The following is a description of a gene set: Scrapie conformation PrPSc to PERK-ATF4 signaling pathway. Pathway ID: N01198. Pathway type: Variant. Pathway class: nt06534 Unfolded protein response. Pathway Definition from KEGG: PRNP* -| BIP -| EIF2AK3 -> EIF2S1 -> ATF4 => DDIT3 species: Homo sapiens Human Gene Set: KEGG_MEDICUS_VARIANT_SCRAPIE_CONFORMATION_PRPSC_TO_PERK_ATF4_SIGNALING_PATHWAY, and this is the list of marker genes: HSPA5, ATF4, EIF2AK3, PRNP, EIF2S1, DDIT3